Given this list of marker genes Map1a, Wdr47, Map1s, Fsd1, Rhoa, Rps3, Snca, Nme7, Atat1, Clasp1, Arhgef7, Fam107a, Hdac6, Chmp4b, Stmn2, Tacc3, Pafah1b1, Gda, Chmp7, Tubb4a (tubulin, beta 4A class IVA), Cdk5r1, Fgf13, Pkd1, Ccdc88c, Mid1ip1, Trim36, Agrn, Mapre2, Katnb1, Map6, Tpr, Trim54, Clip3, Inpp5j, Cdk5rap2, Mapt, Prkaa2, Cep70, Vps4b, Stil, Arhgef2, Diaph3, Ttbk2, Mark2, Apc2, Cep97, Gnai1, Aurkb, Bbof1, Rae1, Plk1, Trpv4, Pak1, Hnrnpu, Cltc, Chmp1b2, Spef1, Camsap2, Epha3, Rp1, Map1b, Atxn7 (ataxin 7), Prune1, Rac1, Senp6, Sgk1, Slc39a12, Rock1, Specc1l, Mapre1, Hspa1b, Togaram1, Arl2, Akap9, Chmp6, Hsph1, Cenpj (NCBI Gene Id 219103), Gas2l1, Bicd2, Gsk3a, Fes, Abl1, Numa1, Chmp1b, Chmp2a, Camsap3, Prkaa1, Dctn1, Tpx2, Tppp, Map9, Dixdc1, Hspa1a, Drg1, Dync1h1, Mapk15, Clip1, Gba2, Mecp2, Kif21a, Parp3, Ripor2, Chmp2b, Ska3, Ckap5, Map2, Cdh5, Gas2l2, Ckap2, Chmp5, Mapk8, Mapre3, Cdk2ap2, Phldb1, Taok1, Chmp4c, Hdgfl3, Htr1a, Phldb2, Chmp1a, Nup62 (NCBI Gene Id 52394), Dyrk1a, Psrc1, Rnf4, Camsap1, Cav1, Mid1, Eml2, Map6d1, Eml3, Met, Spag5, Sass6, Cav3, Gpsm2, Pde4dip, Ccsap, Bora, Wnt3a, Stmn3, Chmp3, Ska2, Ska1, Fkbp4, Tbcd, Stmnd1, Git1, Cib1, Clasp2, Cyld, Stmn4, Slain1, Eml4, Traf3ip1, Ankrd53, Stmn1, Cdkn1b, Spast, Efna5, Rcc1, Gsk3b, Bicd1, Nav3, Apc, Kif18a, Slain2, Bmerb1, here is a description of the gene set: studied in species Mus musculus Any process that modulates the frequency, rate or extent of the formation, arrangement of constituent parts, or disassembly of cytoskeletal structures comprising microtubules and their associated proteins. Mouse Gene Set: GOBP_REGULATION_OF_MICROTUBULE_CYTOSKELETON_ORGANIZATION